The following is a description of a gene set: Reactome Pathway: Cell-Cell communication species: Homo sapiens Cell-to-Cell communication is crucial for multicellular organisms because it allows organisms to coordinate the activity of their cells. Some cell-to-cell communication requires direct cell-cell contacts mediated by receptors on their cell surfaces. Members of the immunoglobulin superfamily (IgSF) proteins are some of the cell surface receptors involved in cell-cell recognition, communication and many aspects of the axon guidance and synapse formation-the crucial processes during embryonal development (Rougon & Hobert 2003).<p>Processes annotated here as aspects of <b>cell junction organization</b> mediate the formation and maintenance of adherens junctions, tight junctions, and gap junctions, as well as aspects of cellular interactions with extracellular matrix and hemidesmosome assembly. <b>Nephrin protein family interactions</b> are central to the formation of the slit diaphragm, a modified adherens junction. Interactions among members of the <b>signal regulatory protein family</b> are important for the regulation of migration and phagocytosis by myeloid cells., and this is the list of marker genes: ITGB4, PSMA3, H3-3A, SNAI1, NPHS1, MDM2, H2BC17, CTNNB1, IL6R, KMT5A, H2AJ, PSMB2, FOXP2, HDAC2, STAT3, PSMD2, POMT1, FOXF1, AGO4, H2AC20, EED, KRT5 (NCBI Gene Id 3852), PSMA5, PCSK6, ANGPTL4, CDH8, IL6ST, CD151, CD2AP, DAD1, SEC11C, PSMB4, ZBTB33, UBB, H4C1, LAMA3, H2BC4, NCK2, H3C15, SPCS3, PRDM8, PSMA2 (NCBI Gene Id 5683), CDH18, JUP, KDM1A, SMARCA4, KIRREL3, CDH17, CADM1, PLEC, DDOST (dolichyl-diphosphooligosaccharide--protein glycosyltransferase non-catalytic subunit), CDH2, TNRC6B (NCBI Gene Id 23112), AMOT, H2BC9, H2BC12L, CLDN22 (NCBI Gene Id 53842), MCRIP1, TCF12, ITGB1, KIRREL2, PRKCSH, ARID1A, SPCS2, CLDN15, PARD6A, LIMS1, SFTPD, H2BC14, CLDN10, CADM3, MAGI2, UCA1, H2AZ2, PSMD6, CSNK2A3, BHLHE22, CLDN7, MIR451A, PTK2 (NCBI Gene Id 5747), CTNND1 (catenin delta 1), SNAI2, RSU1, NCK1, TIAM1, PIK3R1, PSMB1, PXN, H2AC4, NECTIN4, SRC, CDH15, LAMB3, LIMS2, CLDN8, H2BC15, RBBP4, PTK2B, RACK1, ILF3, F11R, PSMC6, ACTN1 (NCBI Gene Id 87), DNM2, FARP2, NECTIN1, CDH24, UBA52, AGO1, PTPN6, H2BC1, CTSL (NCBI Gene Id 1514), PIK3CB, HEYL, AGO3, PVR, UBC, CDH3 (NCBI Gene Id 1001), E, SIRPG, CLDN20, PSMC3, DOCK1, CSNK2B, CLDN3, HDAC1 (histone deacetylase 1), RPN2, FOXA2, CDH1, TWIST2, JAK1, H2AC6, TCF3, MTBP, PSMB6, PSMC5, PARD3, CRB3, RBBP7, DNTTIP1, WASL, H2AX, KIRREL1, RPS27A, CLDN12, TESK1, FOXQ1, BIRC2, AFDN, H2AB1, FLNC, ACTA1, HOXC8, MOGS, TRAF7, SIRPA, ADAM33, H3C1, CLDN23, KLF4 (NCBI Gene Id 9314), CLDN11, SIRPB1, CSNK2A1, PSMD8 (NCBI Gene Id 5714), PSMC4, PRKCI, ZMYM2, EZH2, CTSB, ITGA6, SPTBN1, CLDN18, SP1 (Sp1 transcription factor), CDH12, PSMD3, PARVB, EPS15, KRT14, SDK1, FURIN, H2BC13, ACTB, GRB2, NECTIN3, FYN, CLDN16, PSMA1 (proteasome 20S subunit alpha 1), CDH4, CDH10, IL6, PSMD13, SEM1, BANP, CLDN9, SEC11A, CDH11 (cadherin 11), CDC42, CANX, PSMD1, H2BC21, SDK2, SOX10, MIR10B (NCBI Gene Id 406903), CLDN4, PALS1, ACTC1 (NCBI Gene Id 70), COL17A1, H2AC18, SPCS1, CLDN19, PSMC2, ACTG1, PARVA, ANG, TWIST1, ILK, TMEM258, ACTN2, ANK3, PIP5K1C, POMT2, MIR9-1, DST, TLE1, CDH7, MIR9-3, SFTPA1, H2AC14, WT1, ZEB2, ACTA2 (actin alpha 2, smooth muscle), TYK2, ADAM19, CADM2, FLNA, CDH6, MAPK3, ARHGEF6, CDH5, TYROBP, PSMD12 (NCBI Gene Id 5718), H2BC26 (H2B clustered histone 26), PSMD14, MIR9-2, H2BC5, CDH19, H2BC3, RPN1, MIR200C, CD47, FOXJ2, PIK3CA, SPTAN1, CLDN2, CTSS, ELMO1, PIK3R2, STT3A, CSNK2A2 (casein kinase 2 alpha 2), STRAP, OSTC, CTBP2, ZEB1, ARHGEF4, LAMC2, JAK2, ACTN3, ZNF217, CTBP1, MAPK1, VCL, RNF19B, PTPN11, RELA, NFKB1, PSMD11, PCSK7, TFAP2A, FBLIM1, ACTG2, ADRM1, VAV2, RAC1, ACTN4, PSMA4, SKAP2, TGIF2, CLDN14, TNRC6A, ZC3H12A, PSMD7, AGO2, OST4, SIRT1, PKM, CLDN17, H2AC7, MOV10, PSMB3, CBLL1, CLDN5, GANAB, CDH9, HACE1, SUZ12, CLDN1, PSMB5, KLF9, MYC, PSMA7, CDH13, CTNNA1, TNRC6C, NECTIN2, VASP, PARD6B, PSMB7, H2BC12, PSMA6, CLDN6, XIAP, MPHOSPH8, FERMT2, RB1, NPHS2, H2BC11 (NCBI Gene Id 8970), PSMC1, PATJ, FYB1, ARHGAP32, CASK, IQGAP1, MYCN, SFTPA2, PARD6G